The following is a description of a gene set: Neurotrophins function as ligands for receptor tyrosine kinases of the NTRK (TRK) family, as well as the death receptor NGFR (p75NTR). While all four neurotrophins, NGF, BDNF, NTF3 (NT-3) and NTF4 (NT-4, NT-5, NTF5) can bind to and activate NGFR, they show different specificity for NTRKs. NGF exclusively activates NTRK1 (TRKA). BDNF and NTF4 are high affinity ligands for NTRK2 (TRKB). NTF3 is a high affinity ligand for NTRK3 (TRKC) and a low affinity ligand for NTRK2. Neurotrophins play pivotal roles in survival, differentiation, and plasticity of neurons in the peripheral and central nervous system. They are produced, and secreted in minute amounts, by a variety of tissues. For review, please refer to Lessmann et al. 2003, Chao 2003, and Park and Poo 2013.<br>Human NGF, also knowns as the nerve growth factor, is encoded by a gene on chromosome 1, which produces a single transcript. Nascent NGF protein, pre-pro-NGF, is 241 amino acids long. As pre-pro-NGF enters the endoplasmic reticulum (ER), the signal peptide, consisting of eighteen amino acids at the N-terminus, is cleaved, producing pro-NGF. Two molecules of pro-NGF form homodimers in the ER. After transport of pro-NGF homodimers to the Golgi, 103 amino acids at the N-terminus of pro-NGF are cleaved, producing mature NGF homodimers. Both pro-NGF homodimers and mature NGF homodimers are secreted to the extracellular space. Mature NGF homodimers activate NTRK1 signaling, while NGFR signaling can be activated by both mature and pro-NGF homodimers. Secreted pro-NGF homodimers may be cleaved by extracellular matrix proteases to produce mature NGF homodimers. For review, please refer to Poo 2001, Lu et al. 2005, Skaper et al. 2012, Bradshaw et al. 2015.<br>Human BDNF, also known as brain-derived neurotrophic factor, is encoded by a gene on chromosome 11, which, through the use of 9 alternative promoters and alternative splicing, produces 17 protein-coding transcripts. Most BDNF transcripts result in the same pre-pro-BDNF protein of 247 amino acids, but alternative promoters and different 5' and 3’UTRs allow to fine-tune regulation of BDNF expression at different developmental stages and at different levels of neuronal activity. Similar to NGF, pre-pro-BDNF is processed by proteolytic cleavage in the ER to produce pro-BDNF homodimers. It is unclear whether proteolytic processing of pro-BDNF, to produce mature BDNF homodimers, occurs in the Golgi or in the secretory granules. Extracellular matrix proteases can also cleave secreted pro-BDNF to produce mature BDNF homodimers. Secreted mature BDNF homodimers can activate NTRK2 signaling, while secreted pro-BDNF homodimers can activate NGFR signaling. For review, please refer to Poo 2001, Lu et al. 2005, Skaper et al. 2012, Park and Poo 2013.<br>Human NTF4, also known as neurotrophin-4, is transcribed from a gene on chromosome 19. A single experimentally confirmed transcript produces a pre-pro-NTF4 protein of 210 amino acids. After proteolytic processing in the ER and Golgi, mature NTF4 homodimers are secreted and can activate NTRK2 signaling. For review, please refer to Poo 2001, Skaper et al. 2012.<br>Human NTF3, also known as neurotrophin-3, is transcribed from a gene on chromosome 12. Two NTF3 transcripts have been experimentally confirmed, but only the longer NTF3 splice variant of 270 amino acids has been studied. After proteolytic processing in the ER and Golgi, mature NTF3 homodimers are secreted and can activate NTRK3 signaling. For review, please refer to Poo 2001, Skaper et al. 2012. Reactome Pathway: Expression and Processing of Neurotrophins part of: Signaling by NTRKs studied in species Homo sapiens, and this is the list of marker genes: NGF, PCSK6, FURIN, PCSK5